Given this list of marker genes CADM4, AKT1 (AKT serine/threonine kinase 1), S1PR2, CSNK2B, SIRT2, GALNTL6, TNKS, PRKDC, CHI3L1, GALNT13, STOX1, GALNT4, CEMIP, PARD3, CHEK1, GALNT2, CDK1, NLK, CDK10, DMTN, IRGM, HIPK3, PRKCA, PRKCD, UBE2K, TBK1, LMTK2, EOGT, CDK5R1, MYLK2, TRIM6, EGF, PRKD2, PRKD1, GALNT1, STK39, CAMK2A, TTBK1, ATF2, GALNT3, WNK3, SPHK1, STK11, ACVR1B, GALNT6, GALNT11, GALNT16, MAPK8, MAPK1 (mitogen-activated protein kinase 1), MAP3K10, here is a description of the gene set: Human Gene Set: GOBP_PEPTIDYL_THREONINE_MODIFICATION The modification of peptidyl-threonine. studied in species Homo sapiens